Given this list of marker genes TBX5, TGFB2, PRICKLE1, DHX36, NKX2-5, here is a description of the gene set: Any process that modulates the frequency, rate or extent of cardioblast differentiation, the process in which a relatively unspecialized mesodermal cell acquires the specialized structural and/or functional features of a cardioblast. A cardioblast is a cardiac precursor cell. It is a cell that has been committed to a cardiac fate, but will undergo more cell division rather than terminally differentiating. studied in species Homo sapiens Human Gene Set: GOBP_REGULATION_OF_CARDIOBLAST_DIFFERENTIATION